The following is a description of a gene set: Human Gene Set: MIR3646 studied in species Homo sapiens Genes predicted to be targets of miRBase v22 microRNA hsa-miR-3646 in miRDB v6.0 with MirTarget v4 prediction scores > 80 (high confidence targets). from publication Chen Y, Wang X (PMID 31504780), and this is the list of marker genes: PCSK2, SPTBN1, SLC4A7, BZW1, TASOR2, UBL3, PPTC7, CCT5, WASL, RAI14, ZNF680, POU3F2, HFM1, TSNAX, MKLN1, LTBP2, CCL16, ZBTB6, ELAVL1 (ELAV like RNA binding protein 1), PTPN22, ERCC4, PISD, UTRN (utrophin), PAN3, XKR3, CTBS, RBMS3, PCNX1, TFEC, SNRNP40, MINDY2, TCEANC2, MGAT4A, MYCBP2, PURB, CD69, CRY1, CNTN3, PFDN4, EPCIP, LPAR1, EDIL3, PANK1, CWC25, LIN7A, CREB1, GPC6, KIAA0408, PRKG1, NOVA1, GRID1 (NCBI Gene Id 54547, glutamate ionotropic receptor delta type subunit 1), PNISR, C12orf75, CUL4A, VTA1, CREM, ATP11A, CACNB4, USP15, GCN1, MAPK6, AMBN, KCTD3, CAT, OPA1 (NCBI Gene Id 4976), RBFOX1, TDG (thymine DNA glycosylase), ZNF451, CAB39, RBM4, LAMA1, LPCAT2, ZNF800, MED13L, SEH1L, TENT2, PHIP, SOCS6, ZFHX4, RERE, SMNDC1, RNF144B, FGL2, QKI, WIPF1, PAK3, SNIP1, UBE2D3, MBNL3, DYNC1I2, CREBZF, ITCH, TCEAL7, MEIS2, MTMR4, MATCAP1, TRIM33, KLF12, TMEM164, ITM2A, C21orf91, RIF1, PLXDC2, TRMT10A, CDK6, RHPN2, FSBP, ERMN, STMND1, LATS1, PSMA8, JADE3, TMEM182, TRAK1, E2F4, INO80D, NRG2, GRPEL2, MRPL19, CNOT6L, HIPK1, ZBTB38, STMP1, ARK2N, SMARCAD1, TOX, RNF7, ZNF148, PLEKHA1, RAB30, TP53INP1, ZNF14, LCOR, ARF3, POTEE, SAMSN1, FBXL5, KPNA4, REEP3, ABCC5, CNR1, BNC2, SULT4A1, USP8, IGF2BP3, PTER, SNTB2, KMT2E, PRICKLE3, GXYLT1, KCNV1, ERRFI1, KCTD12, PIAS2 (NCBI Gene Id 9063), CPEB1, OPALIN, GRIP1, HNRNPF, PUS10, IFIT1, DCLK1, ZNRF3, MTUS2, XPO4 (NCBI Gene Id 64328), OBI1 (NCBI Gene Id 86572), SLF2, ASPH, ZFYVE21, SGIP1, GNG4, ERAP1, FAT3, PLEKHS1, GPR34, GDAP1, RHOA, BRWD1, OSBPL3, VAV3, RAPH1, ASPHD2, RAB3B, TCF20 (NCBI Gene Id 6942), FREM1, LARP4, HNF4G, DENND1B, PTBP1, CXXC4, CRLF3, IRAK3, ZNF100, MACO1, NDFIP2, RASA2, PHEX, AJAP1, TRAF3, VGLL3, NKTR, NKIRAS2, CLDN16, CA10, EIF1AX, CD200, SMCO3, ZNF736, ATG5, SEPHS1 (NCBI Gene Id 88214), SP4, SRSF2, GOLGA6A, ERLIN1, SLC38A4, CYREN, LHX8, SENP7, VWA8, RANBP1, ZC3H12B, DLGAP1, TENM1, PLEKHG7, MAP2K4, LRRC75A, SH3BP2, RNF152, KIF2A, SH2D4B, ALOX5, SAMTOR, SPEF2, SRSF1, GSPT2, DPM1, OSGIN2 (oxidative stress induced growth inhibitor family member 2), HNRNPR, KCNA1, NPL, TTF2, PRKCE, PGAM4, PRAMEF13, ELAPOR2, C6orf118, TRUB1, IKZF2, GAB3, THAP1, ZMAT3, CEP97, SNX13, MATR3, PDCD6IP, FILIP1L, DNHD1 (NCBI Gene Id 387750), NEXMIF, AKT3, TMED7, YPEL5, PRAMEF14, FOXN2, NAB1, GOLGA8A, PHF20L1 (PHD finger protein 20 like 1), UBASH3B, TCAF2, PDLIM5, CHM, GOLGA6L9, HYCC2, RELCH, OSBPL8, ZDBF2, SRPK1, ADAMTS5, AAK1, KALRN, ZNF519, SEC61A2, RPGRIP1L, OR9Q1, MDFIC, ABCB5, PABPC5, SSB, RBM22, APPBP2, GABRA1, SEPTIN7, FAM204A (family with sequence similarity 204 member A), GOLIM4, TMCO1, MBTD1, TRIP12, LHFPL6, HNRNPLL, GUCY1A2, INO80C, SORBS1, CUX1, FKTN, KRTAP4-11, HOOK3, ORC4, CARNMT1, FGF12, MXD1, CUL4B, CAMTA1, SETD7, TLCD4, KLHL28, GPR158, RFX7, MYT1, HCN3, STAU1, CBL, GSPT1, ITPR1, RDH10, SH3D19, ZNF280D, EBF1, DNAJB4, ZNF284, BRWD3, VPS29, PRP4K, SVEP1, PRELID2, SLC25A31, OLR1 (oxidized low density lipoprotein receptor 1), PEX3, PIGN, PTPN14, BCL9, TDRP, SEC63, SLC12A2, STRBP, LIMCH1, ARID4B, PLCL1, CCDC144A, UBE2K, MEI4, CCDC186, MSANTD2, RAD1, ANO6 (anoctamin 6), VWA3B, SLC16A7, HERC4, SLC44A1, TMED5, NUP62CL, LCLAT1, FJX1 (NCBI Gene Id 24147), TPCN2, AEBP2, KCMF1, IPCEF1, RASGRF2, MAPRE2, INSYN2A, UBE3B, DLG5, ACTR8, UTY, CEP290, NONO, CERS6, BOLL, KCNMB2, ZIC4 (NCBI Gene Id 84107), SH3TC2, CFAP300, KIF14, EEF1E1, ZNF292, ARFIP1, ZNF322, CALCRL, SF3A1, TIAL1, NPAS3, STK3, PRKAG2, ATAD1, CXCL12, TRIB2, PDLIM4 (NCBI Gene Id 8572), KLHL24, RAB3C, MARCKS, SC5D, CCDC170, MICAL2, SAMD8, ZBTB10, HDAC1, SMURF2, YIPF6, KL, PHC3, BICD1, AXIN2, ICAM5 (NCBI Gene Id 7087), TBC1D32, SGCZ, NAA25, ID4, FSD1L, SDAD1, ZDHHC15 (zinc finger DHHC-type palmitoyltransferase 15), NSL1, SPTY2D1, RALA, TMX4, ARHGAP12, PCLO, YTHDC2, ZFX, CCDC125, BAZ2B, SCAI, HIPK3, GPM6B, TP53TG3D, RCHY1, TMEM135, WAC, APOOL, CUL3, RAB27B, EEF2K, CTHRC1, OTP, SGTB, CCDC89, CBFB, CSNK1G3, REST, GOLGA6L10, SEMA3D, HGF, ACSL3, NRXN1, CNEP1R1, DNAJC27, GCNT1, SCN8A, ZNF320, PRLR, IFT70A, SMARCA5, PIP4P2, SEPTIN10, FZD3, FBXO42, LDHAL6B, CFL2, INTS6, GUCY2C, LIFR, C18orf54, TSC22D2, CFHR2, UNC5D, PRKAA2, IKZF5 (IKAROS family zinc finger 5), AP3B1, EREG, ZKSCAN8, CA8, DHX57, TMEM38B, AKAP6, NMNAT1, COMMD3-BMI1, CHD6, HIPK2, BCAT1, ZMYND11, PIK3CA, SPIN1, SAR1B, SLC30A4, SLC12A1, PAG1, SENP5, FAM133B, ZNF346, NEMF, PCNP, TFPI, FRG2C, ANKRD46, SIGLEC8, POT1 (protection of telomeres 1), RPS6KA6, RNF180, NDUFA4L2, RIMS2, PPP6R3, CDK15, PEX7, CD84, PDE10A, SOCS4, HAUS6, ACTN2, RASGEF1A, TBCEL, HSD17B6 (hydroxysteroid 17-beta dehydrogenase 6), KLLN, SLC30A7, FOXA1, XIAP, WWC2, BCL11B, PDS5B, CD99, DCBLD2, EEA1, WDR33, HPGD, ACKR4, ICE2 (NCBI Gene Id 79664), ZNF227, RAP2B, ZBTB20, KLHL5, PIK3CB, CCDC50, GUCY1A1, SLC1A2, SNAP23 (synaptosome associated protein 23), GATAD1, VPS37A, TRIM36, MMGT1, NR3C1, ZNF365, JMY, ANGPT1, MMP28, ALG5, EDEM3, LOX, SEC23A, SLC16A1, CAPRIN1, EPB41L4B, SLC38A9, PTBP3, TXNDC17, MAP3K20, EBF3, IRS1, GRID2, PPP1R3A, RFX3, ERICH3, MCF2, NREP, GLMN, SCN7A, ONECUT2 (NCBI Gene Id 9480), BMPR2, ATP2B2, LGR4, TRA2B, AMDHD1, BACH2, NRP1, POC1B, KLHL11, NRIP3, CDH11, MTCL3, FRG2, FIGN, CCDC126, FAM168A, FGF14 (fibroblast growth factor 14), DZIP3, CHODL, DPP4, GABRB3, SCAPER, PLCB1, PAFAH1B1 (NCBI Gene Id 5048), DIPK2A, LIN7C, TP53TG3, NETO2 (NCBI Gene Id 81831), FAM199X, SOX21 (SRY-box transcription factor 21), GDAP2, CPEB3, TMPO, UBE2W, WDFY3, RLIM, USP34, SNX19, PTGDR, JPH1, NRIP1, NWD2, CAMK4, GSK3B, GOLGA6B, DZIP1, LARS1, UBA6, SYT14, TMEM170A, TNPO1, SNTG1, GOLGA6L4, PXDNL, RAB28, YTHDF3, VXN, CCNY, PPM1E, PKD2, CLEC12A, DPYD, ADSS2, UBE2D2, MASTL, ZNF780A, MED12L, SCYL2, UGT8, KLHL20, LHCGR, HELZ, TESPA1, CLEC4C, GABRG1, FMO2, RSPH3, KCNMA1, RNF128, AKAP11, LRP2BP, OLFM3, MYNN, IL22RA2, GPNMB, RAD51B, BVES, TP53TG3B, FSTL5, MANSC1, SGCD, GPR85, FNBP1L, PRAMEF1, OGFRL1, MYSM1, LSM8, PCDH17, MAP1B, BMP3, FSD2, BMAL2, BCO2, EPHA5, SRSF10, IL1RAP, SKIL, GYS2, PAX6, CCDC82, NWD1 (NCBI Gene Id 284434), ZNF649, HMBOX1, PHF3, POLK, PRAMEF2, RMND5A, CD86, GADL1, GRSF1, CFHR1 (NCBI Gene Id 82407), KRIT1, LSAMP (NCBI Gene Id 4045), KBTBD7, MAP3K21, IFI44L, SERPINA10, C16orf87, PCDH19, PAPLN, DPY19L4, CLOCK, ARHGAP42 (Rho GTPase activating protein 42, NCBI Gene Id 83935), TMEM98, SKI, SSR1, FRS2, MTM1, SBNO1, CREB5, ZNF704, SPOPL, KRTAP4-8, TMEM236, FFAR4, BUB1, BBS10, CNOT2, KIAA1958, MAPK8, PDK3, NPTX1, MCMBP, BRIP1, POTEJ, EDAR, XPR1, GDF6, KDM7A, EGLN1, PRKACB, DCLK3, ACVR2A, MYT1L, SUMO2, SPATA13, GPC2, CCNK, LRRC40, GPR83, TRIM45, DTWD2, MIGA1, TBK1, ANKH, PRDM11, SNX1, OPRM1, DENND5B, PPP2CB, BCAP29, ARFGEF3, PTPN4, EXOSC3, TTPA, EBF2, KAT6A, GCSH, VHL, VSTM2A, DGKH, TCF4, SOX6, PRDM4, ZMYM4, GOLGA8N, HDAC2, MRPL42, NR2F1, USP47, UBQLN1, CTDSPL2, ASB5, COPS8, RORA, CCDC148, FOXO1, NFAT5, LYVE1, PLCXD3, PLAG1, ATXN2, LGSN, NFYB, CADM2, SCN11A, TET2, XRN1, CFH, POLR3K, ABAT, ABHD13, ITGB8, KCTD9, AKR7A2 (NCBI Gene Id 94395), CGGBP1, MYCT1, RAB21, ROBO1, CTNND2, NIPA1, FER, CLIC5, GPM6A, PGBD2, THRAP3, EYA1, RAG1, TMEM245, STX7, CRACD, SFMBT1, CPNE3, TMEM241, CXADR, GAPVD1, ADIPOQ, PPM1H, TBCA, EPHA4, PLA2G4D, GABPA, R3HDM1 (R3H domain containing 1), CPSF6, EIF5A2, CCDC88A, NPR3, RICTOR, GOLGA8B, PIK3R1, FAM169A, ANKRD50, CDK17, MTMR7, SNAP29, ZC3H8 (zinc finger CCCH-type containing 8), MAP3K2, RGS1, BHMT (NCBI Gene Id 83323), PDE8A, SEL1L, PATZ1, ACTR6, APPL1, ATP7A, AHCYL2, SRI, RSBN1L, ESR1, FMN1, MPP3, LZTFL1, SLC6A15, SNAPC1, FPR3 (formyl peptide receptor 3), SLC39A10, PCMTD1, RSU1, TMEM59 (NCBI Gene Id 9528), RNF145 (ring finger protein 145), MIER3, ADK, MARK1, BPNT2